The following is a description of a gene set: Human Gene Set: DESCARTES_FETAL_THYMUS_ANTIGEN_PRESENTING_CELLS species: Homo sapiens from publication Cao J, O'Day DR, Pliner HA, Kingsley PD, Deng M, Daza RM, Zager MA, Aldinger KA, Blecher-Gonen R, Zhang F, Spielmann M, Palis J, Doherty D, Steemers FJ, Glass IA, Trapnell C, Shendure J (PMID 33184181) Marker genes curated from the annotated cluster as represented in the Descartes Human Gene Expression During Development database. The gene expression program underlying the specification of human cell types is of fundamental interest. The study authors generated human cell atlases of gene expression and chromatin accessibility in fetal tissues. For gene expression, the study authors applied three-level combinatorial indexing to >110 samples representing 15 organs, ultimately profiling ~4 million single cells. The study authors leveraged the literature and other atlases to identify and annotate hundreds of cell types and subtypes, both within and across tissues. Our analyses focused on organ-specific specializations of broadly distributed cell types (such as blood, endothelial, and epithelial), sites of fetal erythropoiesis (which notably included the adrenal gland), and integration with mouse developmental atlases (such as conserved specification of blood cells). These data represent a rich resource for the exploration of in vivo human gene expression in diverse tissues and cell types., and this is the list of marker genes: TYROBP, DAPP1, CD74, P2RY10, MS4A7 (NCBI Gene Id 64230), MS4A1, KCNK13, MCOLN2, CD14, ACOXL, FCRL5, EDARADD, PLAUR, MS4A6A, ABCC3, TASL, TFEC, IGHM, HLA-DRA (major histocompatibility complex, class II, DR alpha), RASGEF1B, SLC8A1, HLA-DRB1, FGL2, ARNT2, IL4I1, IGSF6, IDO2, SLC24A4, MIR155HG, HLA-DOB, RAB31, NFAM1, TMCC3, RGS1, HLA-DPA1, HLA-DRB6, ENSG00000227531, LY86, STRIP2, SIGLEC10, CYRIA (NCBI Gene Id 81553), CTSH, F13A1, GPR141, RASSF4, CYTOR, TLR2, NABP1, SLC9A7, NAAA, FCER1G, TMEM176B (transmembrane protein 176B), LYZ (lysozyme), DNASE1L3, CPVL, MPO, SLC1A3, IDO1, SPI1, GRIK4 (glutamate ionotropic receptor kainate type subunit 4), FGR, HLA-DPB1, BATF3, CLEC9A, ADISSP, LINC00996, IGKC, FSCN1, THEMIS2 (thymocyte selection associated family member 2), GPR132, TSPAN13, SPINT1, WDFY4, ID2, ADAP2, SLC7A7, SLC16A3, CMKLR1, ASPHD2, ICOSLG, EPSTI1, ITGAX, SAMSN1, HLA-DMB, APOBR, SRGN, CLIC2, MPEG1, CLEC7A, MARCHF1, MYO1F, CXCL9, CXCL10, PLD4, BCL2L14 (NCBI Gene Id 79370), C1QA, PLEK, S100B, IL10RA, QPCT, CD68, FBXO27, PTAFR, CPPED1, IL6R, LRRK2, ZNF366, CD86, BIRC3, CLNK, CHN2, OTULINL, LY96, GFRA2, IL1RN, P2RY14, IL18R1, CCL17, GPR157, ENSG00000230773 (NCBI Gene Id 105374593), SLC15A3, IRF8, ABCC4, CD163L1, PLB1, MMP9, HLA-DRB5, PLCB2, EBI3, SLAMF7, CSF2RA, ARHGAP22, GNAO1, IL18, RYR1, FLT3, ACSM3, NRG4, KDM2B, ANKRD55, PAX5, CYBB, HCK, LGMN, TLR10, SLAMF8, NFKBIE, HLA-DQB2, TSPAN33, MMP25, CD84, P2RY13, TFEB, UNC93B1, CCL22, ADAM8, P2RY6, CCL19, MAFB, TRAF1, CST7, CTSS, FUCA1, ACSL1, C1QB, CEBPG, KYNU, MNDA, CD83, CD80, ENSG00000231873, ALOX5, WNT5B, FGD2, SEMA4A